The following is a description of a gene set: studied in species Homo sapiens In this study we compared the effects of IL-2, IL-15, and IL-21 on the gene expression, activation of cell signaling pathways, and functional properties of cells derived from the CD4+ cutaneous T-cell lymphoma (CTCL). Whereas both IL-2 and IL-15 that signal through receptors that share the common gamma chain and the beta chain modulated the expression of >genes, IL-21 that signals via the receptor also containing gamma chain up-regulated <genes. All three cytokines induced tyrosine phosphorylation of Jak1 and Jak3. However, only IL-2 and IL-15 strongly activated STAT5, PI3K/Akt, and MEK/ERK signaling pathways. In contrast, IL-21 selectively activated STAT3. Whereas all three cytokines protected CTCL cells from apoptosis, only IL-2 and IL-15 promoted their proliferation. The effects of the cytokine stimulation were Jak3- and Jak1-kinase dependent. These findings document the vastly different impact of IL-2 and IL-15 vs. IL-21 on malignant CD4+ T cells. They also suggest two novel therapeutic approaches to CTCL and, possibly, other CD4+ T cell lymphomas: inhibition of the Jak1/Jak3 kinase complex and, given the known strong immunostimulatory properties of IL-21 on CD8+ T, NK, and B cells, application of this cytokine to boost an immune response against malignant CD4+ T cells. Human Gene Set: GSE8685_IL2_STARVED_VS_IL21_ACT_IL2_STARVED_CD4_TCELL_DN Genes down-regulated in Sez-2 cells (T cell lymphoma): untreated versus IL21. from publication Marzec M, Halasa K, Kasprzycka M, Wysocka M, Liu X, Tobias JW, Baldwin D, Zhang Q, Odum N, Rook AH, Wasik MA (PMID 18281483), and this is the list of marker genes: FAM220A, SCAI, RWDD3, FGD3, ENPEP, SLC39A4, SYMPK, KRBA1, PPP2R5E, PRDM2, SETD4, MAP2K6, TNIK, XRCC5, DND1, RPL18A, ZNF628 (NCBI Gene Id 89887), CSNK1G2, NIPAL3, CNIH2, AFTPH, ADGRB2, TSPYL4, ITLN1, AKT1, DVL1, NEURL1B, LRMDA, NDFIP2, MARK4 (NCBI Gene Id 57787), NSUN5, ENO1, HTRA3, RFXANK, DSE, C22orf39, MCOLN2, HIF1A, CDR2, SECISBP2L, TOMM34, PHC1, DNAJB13, TTLL11, ARG2, CHKB, RAB35, DDX24, USP40, DENND1B, TPM3, RPLP0, TMUB2, SARS1, SLC38A9, NDUFA7, FBXO4, PIERCE1, BRAT1, NCAPH, BRWD3 (NCBI Gene Id 254065), SOAT2, MRGBP, SLX4, MIER2, MYOM2, UNC45A, TMEM106A, TONSL, PLEKHM1, MAP2K2, CSRP1, POLG, TEAD2, SLC5A10, ZNF597, SEC31A, RABGAP1L, SLC46A3 (solute carrier family 46 member 3), STYK1, SLC37A2, INPPL1, FLI1, BCDIN3D, ZNF653, ADD3, CBX7, TSSC4, SUPT6H, HGS, ACRBP, ZNF658 (NCBI Gene Id 26149), WDR38, DNM2, MGRN1, SREBF1, QPRT, EPHB6, TOR2A, MMP9, GLIPR2, FBXL8, STRADA, CTSO, MVK, ELK3, RAB29, RHOT2, PRDM10, GRM4, JMJD7-PLA2G4B, MXD3, MAGEF1 (NCBI Gene Id 64110), RABEP1, PSENEN, RPL17, NFKBIB, WDR81, HSPA1B, LGALS3BP, MIS12, TGM4, WRAP53, SLC25A29, TUBB2B, PCED1B, RET, CAGE1, CAMSAP2, LIMK2, NT5E, TMOD4, LPIN2, ZC3H11A, SMG7, MAP3K11, MRPS21, ANKLE1, VIRMA, MXRA7, DDX11, LFNG, GPR68, GPAA1, MAPRE2, LRIG2, SERINC5, SHB, ALDH1L1, ZDHHC24, SOCS5, SLC4A2, ANKRD50, GET3, S100PBP, SLCO2B1, ZNF23, TAF8, CDK5RAP2, PNKP, SULT2B1, DGKD, CHD7, TBC1D1, TMEM222, FOXD2, ANKRD13D, SIRPB1, COG1, LRRC75A, FARP2 (FERM, ARH/RhoGEF and pleckstrin domain protein 2), COCH, GPM6B, PTPN4, NIBAN2, CYB5D2, RPL13, NAA80, NXT2, HIVEP1, SNTB2, TMCO6, MTURN, ASB1, POU6F1, PTPN5, SUSD1, NOSIP, DDT, HPS5, YPEL1, IRF7, BTBD7, CHERP, IP6K2, TRAF2, DONSON, TMEM140, WWP1 (WW domain containing E3 ubiquitin protein ligase 1), GNA11